Given this list of marker genes PFDN2, VPS26C, TFIP11, INPP5A, LY9, CLNS1A (NCBI Gene Id 1207), CXCL17, DGKA, WASHC5, UGGT1, SPRYD4, TERC, UNK, MAPK1, VAPB, STEAP2, ANXA5, CLTC, SNORD38A, TRAFD1, CABIN1, HDAC4, POLR1C, PRAME, AFG3L1P, SPATA13, MYO1F (NCBI Gene Id 4542), CETN2, KPTN, ECI1 (NCBI Gene Id 1632), SYNRG, AP2M1, JOSD1, KDM1B, KANSL3, RTRAF, ARHGAP27, CSNK2B (casein kinase 2 beta), IFI35, GNB1, MPPE1 (NCBI Gene Id 65258), SLC9A1, RPL13A, HGS, LHPP, ZC3HC1, ARHGEF18, ERAP1, TBL1X, ERCC3, LZTR1, RPL5, BSDC1, JMJD6 (NCBI Gene Id 23210), TENT5A, PSMF1, CNP, ACSS2, ANAPC2, TMEM212, FAM3C, VHL, RRP36, CHMP7, ADI1, GCN1, GART, GLRX, VIPR1, NRP1, GTPBP1, RHOH, RNF41, PSME4, CLP1, DGKD, MYH9, CLDN12, PEPD (NCBI Gene Id 84738), SKIC2, GPATCH4, HCLS1, DDX54, TRIR, SIAE, UBTF, EIF3H, PHF8, AUP1, HSD17B10, VPS26B, LAPTM5, LY6S, AZI2, EEF2, TBX21, CAP1, L3MBTL2, GRPEL1, DCAF11, IQGAP1, RMND5B, RORA, ANKRD6, PPP1R14B, CMAS, TMEM41B, MTA2, ELOVL5, NPC2, GOSR2, NCK1, SUPT5H, PYGB, TMED2, CYTIP, IP6K1, ABLIM1, ABCG1 (ATP binding cassette subfamily G member 1), NDUFS2, RHOA, CBY1, PAPOLA, XPOT, TSPO, PPP1R10, TWF2, GSTP1, COQ9, ETS1, KPNA4, DCTN1, RPL34, ZBTB8A, GNPAT, TOM1, CTSD, TAF6, MAP1LC3B, TMCO6, STRAP, CXCR3, FRMD4B, BET1L, POMT2, RASSF3 (Ras association domain family member 3), ACTB, SNAP29, TEC, NCKAP1, IRF9, ACAD9 (acyl-CoA dehydrogenase family member 9), TMEM256, DOCK8, CAPZB (capping actin protein of muscle Z-line subunit beta), RACK1, CRYBG1, ARHGAP1, NSDHL, CCRL2, SKA2P1, LLGL2, ASL, RAP2C, RNPEP, IGBP1, CBX4, NUCB1, FKBP5, NFKB2, ALDOA, C11orf68, PRPF6, TRAPPC9, PLD3, LBH, SND1, MID1IP1, CD163L1, SLC25A32, DHX8, VASP, here is a description of the gene set: The transcription factor FoxP3 partakes dominantly in the specification and function of FoxP3+ CD4+ T regulatory cells (Tregs), but is neither strictly necessary nor sufficient to determine the characteristic Treg transcriptional signature. Computational network inference and experimental testing assessed the contribution of several other transcription factors (TFs). Enforced expression of Helios or Xbp1 elicited specific signatures, but Eos, Irf4, Satb1, Lef1 and Gata1 elicited exactly the same outcome, synergizing with FoxP3 to activate most of the Treg signature, including key TFs, and enhancing FoxP3 occupancy at its genomic targets. Conversely, the Treg signature was robust to inactivation of any single cofactor. A redundant genetic switch thus locks-in the Treg phenotype, a model which accounts for several aspects of Treg physiology, differentiation and stability. Human Gene Set: GSE40274_IRF4_VS_FOXP3_AND_IRF4_TRANSDUCED_ACTIVATED_CD4_TCELL_UP Genes up-regulated in CD4 T conv over-expressing: IRF4 versus IRF4 and FOXP3. species: Homo sapiens from publication Fu W, Ergun A, Lu T, Hill JA, Haxhinasto S, Fassett MS, Gazit R, Adoro S, Glimcher L, Chan S, Kastner P, Rossi D, Collins JJ, Mathis D, Benoist C (PMID 22961053)